Given this list of marker genes DECR2, SH3BP2, BLK, DEFB4A, CYP4B1, PHB1, JAG1, ZNF3, DOCK7, CELA2A, CELA1, SPESP1, FEZF1, CD1D, LPIN1, TUSC2, C17orf100, FKTN, TGFBI, SESN2, SCN2A, VILL, GLIPR1, TMEM74, CLEC1B, KIF9, TP53INP1, BATF3, DTX1, TMEM131, METTL25, BCO2, RPLP1, ENPP2, DISP2 (NCBI Gene Id 85455), HOXC4, CTF1, EML5, SEPTIN8, FXYD4, FEZ1, ACKR1, THY1, MTFR1L (NCBI Gene Id 56181), ZNF35, IL17A, KIAA1549 (KIAA1549), PLA2G7, PKD1L2, CDK5R2, TLR5, TMEM150C, ABHD14B, TMEM215, CDKN2B, SYNE4, DLX4, SLC25A13, TAL1 (NCBI Gene Id 6886), CDH17, SLC38A2, MAGI1, PNLIP, SIRT4, CD7, NECTIN2, CCR3, MAPK8IP1, NCALD, RND1, TRIQK, MCCC1, EFCAB2 (NCBI Gene Id 84288), ALPK2, HOXA7, APOE, CUL9, GCA, CLEC6A, GP2, EYA3, KCNJ16, LIAT1, DUS4L, ZNF146, DENND2B, STIM1 (NCBI Gene Id 6786), CDC14B, PROCR, HOOK3, ADAMDEC1, EPB41L3, PREB, DNAJA4, BMAL1, AP2B1, PNN, PAPSS2, NFAT5, CSF3, TREML4, SH3PXD2A, BCAS1, JMY (junction mediating and regulatory protein, p53 cofactor), SLAMF6, MR1, ADGRG5, ZNF580 (zinc finger protein 580), PILRB, TNFRSF17, TMEM200C (transmembrane protein 200C), CHMP5, ABHD6, MYO1G, C1orf216, RPRD1A, MPV17 (mitochondrial inner membrane protein MPV17), FASLG, TMEM158, GRIK2, DLG3, ESR1, MAX, ADAM8, KYNU, NAV1, KLKB1, MALT1, P3H3, CD80, ATOX1, UNC13B, NKX2-1, MPZ, SLC26A10P, STAU2, CACNG8, MIA, ESAM, S100A3, ITGAX (integrin subunit alpha X), SIX4, RASSF6 (Ras association domain family member 6), SLC10A6, OOSP2, RBMS2, APPL2, PLPP5, PLA2G2A, TNS1, HARS2, VEGFA, TNFAIP2, PXDC1, C20orf141, DUS3L, UGCG, DZIP1L, SLC26A6, VAPB, ZNF532, MEFV, GAB1, L3MBTL3, MDN1, SIX3, TBC1D8B (TBC1 domain family member 8B), CIB2, TSPAN13, UTP25, SCN3A, CLEC4F, ZNF365, SKIC3, FZD8, SPIC, ENPP5, RPS8, IRX1, EXOC6B, DKK2, DLG2, FYB1, NTPCR, FLAD1 (flavin adenine dinucleotide synthetase 1), ADCK1, PCDH19, DDX47, PDE9A, SNX11, ST14 (ST14 transmembrane serine protease matriptase), ADAM19, SUN3, KLK8, ICOS, RYR3 (NCBI Gene Id 6263), ARHGAP42, PCMTD2, GPN3, TEX101, here is a description of the gene set: Human Gene Set: GSE12392_WT_VS_IFNB_KO_CD8A_POS_SPLEEN_DC_DN from publication Zietara N, Łyszkiewicz M, Gekara N, Puchałka J, Dos Santos VA, Hunt CR, Pandita TK, Lienenklaus S, Weiss S (PMID 19581626) Type I Interferons encompasses a large family of closely related cytokines comprising of at least 13 IFN-α isotypes and single IFN-β. Both IFN-α and IFN-β exert their activity through a common receptor IFNAR. Type I Interferons have broad regulatory effects and various subtypes of dendritic cells are influenced by this cytokines. In our study we asked question whether the low, constitutive levels of type I Interferons produced under steady state conditions are important for proper function of splenic conventional dendritic cells. studied in species Homo sapiens Genes down-regulated in CD8A+ splenic dendritic cells: wildtype versus IFNB1 knockout mice.